Given this list of marker genes Spata33, Gk2, Hsp90aa1, Irgc, Ppp3r2, Ppp3cc, Ak2, here is a description of the gene set: The tightly packed helical sheath of ATP-producing mitochondria restricted to the midpiece of the sperm flagellum. studied in species Mus musculus Mouse Gene Set: GOCC_SPERM_MITOCHONDRIAL_SHEATH